Given this list of marker genes KCNJ2, KCNJ1, ARMC5, CLCNKB, SCNN1A, KCNJ5, SCNN1B, SCNN1G, TERT, CYP11B2, CDKN2A, CYP11A1, BSND, KCNJ10, SLC12A3, CYP11B1, CLCN2, KCNJ16, NR3C2, KDM1A, CACNA1D, OCRL, SLC12A1, CTNNB1, INSR, GNAS, TP53, PRKAR1A, ZNRF3, SLC26A3, CLCNKA, CACNA1H, here is a description of the gene set: Human Gene Set: HP_INCREASED_CIRCULATING_ALDOSTERONE_CONCENTRATION Increased circulating aldosterone concentration Overproduction of the mineralocorticoid aldosterone by the adrenal cortex. studied in species Homo sapiens